The following is a description of a gene set: species: Mus musculus Table S2: Representative genes of each cell cluster from publication Zhang L, Long W, Xu W, Chen X, Zhao X, Wu B (PMID 35669188) Mouse Gene Set: ZHANG_UTERUS_C14_ENDOTHELIAL_MMRN1_HIGH_CELL, and this is the list of marker genes: Thy1, Gpm6a, Stab1, Selenop, Gngt2, Serpine2, Fgl2, Upk3b, Lyve1, Ifitm3, Fth1, Fxyd6, Cd151, Plec, Ctnna1 (catenin alpha 1), Tm4sf1, Olfm1, Crip2, Ecscr (endothelial cell surface expressed chemotaxis and apoptosis regulator), Egfl7, Ltbp4, Txnip, Gnas, Hes1, Cavin2, Mmrn1, F11r, Esam, Elk3, Flt4, Cd9, Aplp2, Timp3, Ipo11, Prelp, Dusp2, Cyb5r3, Cav1, Nrp2, Rab11a, Lims1, Jup, Arl4a, Cldn5, Gng11, Hjurp